Given this list of marker genes BMAL2, LINC02422, ERGIC2, YARS2, PTHLH, BMAL2-AS1, ALG10, PKP2, DENND5B-AS1, RESF1, LINC00941, OVCH1, RPL13AP22, C12orf71BP, BICD1-AS1, FGFR1OP2, RPL31P50, ASS1P14, MRPS35-DT, RNA5SP354, DDX11, IFT57P1, ENSG00000257176, TMTC1, DENND5B, RN7SKP15, SNORA75 (NCBI Gene Id 654321), ETFBKMT (electron transfer flavoprotein subunit beta lysine methyltransferase), TSPAN11-AS1, IPO8, TSPAN11, ANKRD49P2, LINC02386, DUX4L27 (double homeobox 4 like 27 (pseudogene)), RNU6-618P, RNU4-54P, MANSC4, RARS1P1, CAPRIN2, RNA5SP355 (NCBI Gene Id 106479009), RNU5F-4P, REP15, DDX11-AS1, SINHCAF, CCDC91, RPL35AP27, H3-5 (H3.5 histone), OVCH1-AS1, SYT10, RNA5SP357 (RNA, 5S ribosomal pseudogene 357), SMCO2, MREGP1, RPL29P27, RNU6-400P, KLHL42, ENSG00000306838, ITPR2-AS1, RNU6-494P, MED21, STK38L, ITPR2, BICD1, DNM1L, LINC02963, MRPS35, RPL12P32, TM7SF3-AS1, RPL21P99, TM7SF3, FAR2, INTS13, RNU6-472P, PPIAP44, AMN1, RNU6-1069P, RNA5SP356, ENSG00000308619, AK4P3 (adenylate kinase 4 pseudogene 3), HMGB1P49, FGD4, FLJ13224, C12orf71, PPFIBP1, TUBB8P4, LINC02387, AK6P1, STMN1P1, here is a description of the gene set: Human Gene Set: chr12p11 species: Homo sapiens